Given this list of marker genes Rgs12, Gnas, Rgs7, Rgs1, Drd1, F2rl1, Htr1a, Pkd1l2 (NCBI Gene Id 76645), Adrb2, Lpar3, Nucb1, Igf2r, Crhr1, Gpsm1, Ric8a, F2r, Ppp5c, Gpsm2, Lpar1, Plcd4, Myh9, Rgs2 (regulator of G-protein signaling 2), Htr2b, Nucb2, Ccdc88c, Drd2, Igf1r, Rgs14, Rgs4, Adgrv1 (NCBI Gene Id 432787), Oprm1, Rgs19, Rgs10, Kcnj6, Gas2l2, Rgs22, Drd5, Rgs8, Ccdc88a (NCBI Gene Id 77927), Ric8b, Sash1 (SAM and SH3 domain containing 1), Gria1 (glutamate receptor, ionotropic, AMPA1 (alpha 1)), here is a description of the gene set: Mouse Gene Set: GOMF_G_PROTEIN_ALPHA_SUBUNIT_BINDING studied in species Mus musculus Binding to a G-protein alpha subunit. The alpha subunit binds a guanine nucleotide.